Given this list of marker genes MACROH2A2, BDH1, FGL1, MT1H, COX10, ELOVL6, COX4I1, NOP10, UBE2C, F11R, RPL5, NSMCE1, ME2, PLSCR3, MVD, LAMA5, DPYD, SNRPF, ADSL, MAD1L1, SMARCE1, WIPF1, SNRPD3, TGFB1I1, OS9, ARF3, SHMT2, CSTB, CHEK1, ADGRG1, H3-3B, here is a description of the gene set: The RNA-binding protein TIAR (related to TIA-1) was shown to associate with subsets of mRNAs bearing U-rich sequences in their 3' untranslated regions. TIAR can function as a translational repressor, particularly in response to cytotoxic agents. Using unstressed colon cancer cells, collections of mRNAs associated with TIAR were isolated by immunoprecipitation (IP) of (TIAR-RNA) ribonucleoprotein (RNP) complexes, identified by microarray analysis, and used to elucidate a common signature motif present among TIAR target transcripts. The predicted TIAR motif was an unexpectedly cytosine-rich, 28- to 32-nucleotide-long element forming a stem and a loop of variable size with an additional side loop. The ability of TIAR to bind an RNA oligonucleotide with a representative C-rich TIAR motif sequence was verified in vitro using surface plasmon resonance. By this analysis, TIAR containing two or three RNA recognition domains (TIAR12 and TIAR123) showed low but significant binding to the C-rich sequence. In vivo, insertion of the C-rich motif into a heterologous reporter strongly suppressed its translation in cultured cells. Using this signature motif, an additional approximately 2,209 UniGene targets were identified (2.0% of the total UniGene database). A subset of specific mRNAs were validated by RNP IP analysis. Interestingly, in response to treatment with short-wavelength UV light (UVC), a stress agent causing DNA damage, each of these target mRNAs bearing C-rich motifs dissociated from TIAR. In turn, expression of the encoded proteins was elevated in a TIAR-dependent manner. In sum, we report the identification of a C-rich signature motif present in TIAR target mRNAs whose association with TIAR decreases following exposure to a stress-causing agent. species: Homo sapiens Human Gene Set: KIM_TIAL1_TARGETS Top scoring genes whose transcripts bound TIAR1 in extracts from RKO cells (colon cancer). from publication Kim HS, Kuwano Y, Zhan M, Pullmann R Jr, Mazan-Mamczarz K, Li H, Kedersha N, Anderson P, Wilce MC, Gorospe M, Wilce JA (PMID 17682065)